The following is a description of a gene set: The chemical reactions and pathways resulting in the formation of tetrahydrobiopterin, the reduced form of biopterin (2-amino-4-hydroxy-6-(1,2-dihydroxypropyl)-pteridine). It functions as a hydroxylation coenzyme, e.g. in the conversion of phenylalanine to tyrosine. studied in species Homo sapiens Human Gene Set: GOBP_TETRAHYDROBIOPTERIN_BIOSYNTHETIC_PROCESS, and this is the list of marker genes: SPR, DHFRP1, QDPR, DHFR, PCBD2, PCBD1, GCH1, PTS